The following is a description of a gene set: Human Gene Set: GOCC_FIBRILLAR_CENTER A structure found most metazoan nucleoli, but not usually found in lower eukaryotes; surrounded by the dense fibrillar component; the zone of transcription from multiple copies of the pre-rRNA genes is in the border region between these two structures. studied in species Homo sapiens, and this is the list of marker genes: FOXA1, PAK6, RPS6KA6, DAB2, RAI14, RPP38, CASP7, NONO, CDCA7L, TTC8, LIPA, MRI1, ESRRA, DCAF1, SMARCA5, CCR2, MBD6, EEF1D, ATP5MJ, POLR1G, AFF4, FOXL2NB, APEX2, OTP, DDX46, KDM4A, NOP58, SYNE2, UTP4, YY1AP1, MLLT1, DEAF1, CAMK4, KIF7, LBR, NOLC1, LEO1, POLR2F, SELENBP1, DSN1, EZR, TRIM41 (NCBI Gene Id 90933), URB1, RGS22, WDR43, RPAIN, KLF6, MTDH, NRIP1, RAE1, KMT5B, POLR1E, ZNRF2, TAF4B, SNRPB2, RNMT, NFKBIE, CD2AP, PAF1, SMARCB1, HEATR1, SAMD4A, EXOSC8, BNC2, WDR33, TERF1, TRIM27, HERC4, SPECC1, RSAD2, FHIT, ARHGAP32, IMP4, ORC6, SPATA2 (spermatogenesis associated 2), JAZF1, FKBP6, ZNF174, IP6K2, NEDD1, RERG, STAG2, CSNK2B, AKNA, TTF1, NUFIP1, BCL9L, GTF3C3, KDM5D, NHEJ1, RREB1, PLRG1, NUAK1, ANKRD1, IP6K1, TXNRD1, TIMM13, DKC1, THAP1, NR4A1, MRPL23, PSPC1, UBTF, INO80C, STN1, METTL5, POLR1C, POLR1B, TAX1BP3, SAP30L, COIL, E2F5, UBD, SNAI1 (snail family transcriptional repressor 1), TCOF1, STOX1 (NCBI Gene Id 219736), AGER, FBL, USO1, FBLIM1, TRAF3IP1, CC2D1A, NFIC, GAR1, ACACA, EIF3L, NOP56, DCLRE1A, TAF1C, UTP15, MAP3K14, PEX14, FBLL1, FOXJ2, HOXB5, ARHGAP33, SMARCA4, NFIB, SIRT1, TRAF4, SP140, TRERF1, CHCHD1, SESN1, DUSP11, PRMT7, SMAD7, ZNF415, FAM111A, TIMM44, SMUG1, NOP53, CDK7, CEMIP, EN2, KIT, TOP1, BTBD10, CD2BP2 (CD2 cytoplasmic tail binding protein 2), PAFAH1B2, MALT1